The following is a description of a gene set: Human Gene Set: HP_ATRESIA_OF_THE_EXTERNAL_AUDITORY_CANAL Absence or failure to form of the external auditory canal. species: Homo sapiens Atresia of the external auditory canal, and this is the list of marker genes: STAG2, SMC3, TP63, SF3B2, FKTN, GRIP1, FAT4, SMC1A (structural maintenance of chromosomes 1A), FREM2, TSHZ1, HDAC8 (NCBI Gene Id 7492), SMCHD1, ORC1, PAX1, TSR2, GMNN, RAD21, KMT2D, ATP6V1B2, POMT2, TBC1D24, POLR1B, TCOF1, CDC6, TWIST2, EFTUD2, GPRASP2, FGFR2, KIF15, FKRP (fukutin related protein), POMT1, POLR1C, SIX1, HOXA2, GLI3, GSC, ORC6, NIPBL, SIX5, FRAS1, NOTCH3, FANCI, CDT1, DDR2, CDC45, BRD4, ORC4, SNRPB, ERBB3, RPS26, SF3B4 (splicing factor 3b subunit 4), TAF6, LARGE1, RPL26, DCHS1, POLR1D, EYA1, RPL11